The following is a description of a gene set: Human Gene Set: WP_MAP3K1_ROLE_IN_PROMOTING_AND_BLOCKING_GONADAL_DETERMINATION studied in species Homo sapiens MAP3K1 role in promoting and blocking gonadal determination, and this is the list of marker genes: GSK3B, GADD45G, ROCK1, SRY, FGF9, SOX9, FOXL2, FGFR2, FRAT1, MAP3K1, MAPK1, AXIN1, CTNNB1, WNT4, MAPK11, MAP3K4, RHOA